Given this list of marker genes Hcn3, Cnga2, Cnga4, Cnga3, Cngb3, Cngb1, Hcn1, Pex5l, Hcn4, Hcn2, Cnga1, Aqp1, here is a description of the gene set: Mouse Gene Set: GOMF_CYCLIC_NUCLEOTIDE_ACTIVATED_MONOATOMIC_ION_CHANNEL_ACTIVITY Enables the transmembrane transfer of an ion by a channel that opens when a cyclic nucleotide has been bound by the channel complex or one of its constituent parts. studied in species Mus musculus